The following is a description of a gene set: studied in species Mus musculus Reactome Pathway: Ca2+ activated K+ channels This event has been computationally inferred from an event that has been demonstrated in another species.<p>The inference is based on the homology mapping from PANTHER. Briefly, reactions for which all involved PhysicalEntities (in input, output and catalyst) have a mapped orthologue/paralogue (for complexes at least 75% of components must have a mapping) are inferred to the other species. part of: Potassium Channels electronically inferred by orthology from the curated human pathway, and this is the list of marker genes: Kcnn1, Kcnn3, Kcnmb1, Kcnn4